The following is a description of a gene set: studied in species Homo sapiens Marker genes curated from the annotated cluster as represented in the Descartes Human Gene Expression During Development database. The gene expression program underlying the specification of human cell types is of fundamental interest. The study authors generated human cell atlases of gene expression and chromatin accessibility in fetal tissues. For gene expression, the study authors applied three-level combinatorial indexing to >110 samples representing 15 organs, ultimately profiling ~4 million single cells. The study authors leveraged the literature and other atlases to identify and annotate hundreds of cell types and subtypes, both within and across tissues. Our analyses focused on organ-specific specializations of broadly distributed cell types (such as blood, endothelial, and epithelial), sites of fetal erythropoiesis (which notably included the adrenal gland), and integration with mouse developmental atlases (such as conserved specification of blood cells). These data represent a rich resource for the exploration of in vivo human gene expression in diverse tissues and cell types. Human Gene Set: DESCARTES_MAIN_FETAL_SYNCYTIOTROPHOBLASTS_AND_VILLOUS_CYTOTROPHOBLASTS from publication Cao J, O'Day DR, Pliner HA, Kingsley PD, Deng M, Daza RM, Zager MA, Aldinger KA, Blecher-Gonen R, Zhang F, Spielmann M, Palis J, Doherty D, Steemers FJ, Glass IA, Trapnell C, Shendure J (PMID 33184181), and this is the list of marker genes: CYP4F35P, SLC25A43, SPECC1P1, CDK2, FOXO4, ARL15, LINC02327, NFE2L3, ENSG00000256615, ENSG00000251095, LINC01205, HS6ST2, ATP6V1C2, SLC13A4, L1TD1 (LINE1 type transposase domain containing 1), ZFAT, LINC00308, CNNM2, NEDD4, PTPN11P1, NAA11, HSPD1P6, ANKRD20A5P, MIR4300HG, LINC00882 (long intergenic non-protein coding RNA 882), LINC01418, PDE4B-AS1, TUBA5P, CCR3, LINC02055, ZBTB46-AS1, GNA12, MTARC1, SIGLEC6, SMARCA2-AS1, GABRE, RPIA, LINC01087, VSTM5, ZNF354B, LATS2, LINC02899 (long intergenic non-protein coding RNA 2899), LINC02484, USP25, BRDT, AADACL2-AS1, LIN28B, LINC00491, LINC02435, CROT, LINC01524, TTC12-DT, CSNK1A1P1, VGLL1, LINC02840, ZNF799, MIR3171HG, SLC38A9, HOMER1, LINC01687 (NCBI Gene Id 101927843), MAP7D2, LINC02750, PRKCH-AS1, DNMT1, LINC01448, TMEM150C, CCDC54-AS1, SP6, FAM118A, ZNF415P1, ST7-OT4, HERC2P3, MB21D2, ENSG00000232234, OFCC1, TEKT4P2, SNHG27, SPINDOC, SLC13A3, OR8G1, ITGB4, GRAMD2A, AP1S3, ZFX, LINC01446, RNU6-301P, POTEC, SLC19A1, ZNRF3-IT1, FBN2, TRIML2, MME, CCDC32, ADAMTS19, LINC02864, TTPA, TENM3, ZSCAN4, RCOR1, RNU6-698P, GLDC, AMOT, LINC01090, SLC27A2, TPK1, RAP2C-AS1, SMARCA2, RP2, SND1, LINC02583, KANK1, LINC01162, SPACA6-AS1 (NCBI Gene Id 102238594), ATP10D (NCBI Gene Id 57205), LINC01194, LARGE2, ENSG00000261838, PCOLCE2, TDRP, STRA8, POLI, CAMK2G, ENSG00000260378, LINC01203, SLC35D1, MME-AS1, ACSS1, MAST4-AS1, HIC2, LATS2-AS1, ZNRF3, GGH, LINC01591, CTB-1I21.1, BAGE2, TMEM254-AS1, ST8SIA6-AS1, TRIM5, LINC01990, PCAT7, EPB41L3, MBNL3, ANAPC1P1, NOX5